Given this list of marker genes CLEC3B, SLITRK2, ACTN2, GCN1, SPACA3, NOS1, RAB6B, ADGRE4P, HNRNPH3 (NCBI Gene Id 3189), SUFU (SUFU negative regulator of hedgehog signaling), MIR185, CES2, COL14A1, BAALC, IGLL1, ADAT1, ALPK2, FOXN3, TRAM2, STAT3, POLR1D, FUT11, MYLIP, PAQR5, PHOX2B (NCBI Gene Id 8929), CAPZA3, DDX5, PJVK, ODAD4, MEGF6, ELMOD1, WDR33, SLC30A8, SPATA3, KRT6A (keratin 6A), MTHFD2L, AGAP2, TSC22D3, NUP210, SLC20A1, KBTBD12, SLC23A2, MAPDA, RHBDL1, ADCY8, TRIM40, C5AR2, GPC2, LRRC7 (NCBI Gene Id 57554), P2RX2, ANK2, ELN, PYGM, DYRK1B, ECT2L, GSDME, ANKRD61, AMDHD1, HEATR5B, FGF23, ETV2, FAT3, SNX29, XKR7, ANKRD60, SLC25A18, GDPD3, AGER, SLC6A5, FAM170B, SEMA3D, ZFP3, KDSR, WAS, SLC27A5, FGD5, SF3B1 (splicing factor 3b subunit 1), MIR376B, RGS7, KHSRP, RNF123, TRAK1, NOXO1, GLDN, SLC16A2, PAF1, MRAP2, VAMP2, CYB561D1, PRRT1, FAM83A, CNGA1, ZNF483, COX8BP, CREG2, HECW1, FHOD1, FRMD6, MIR337 (NCBI Gene Id 442905), CPEB1, NAA11, IDS, PSD4, FAM114A2, ZBTB44, NDOR1, TNNI3, NIPAL1, TMCC1, GALP, SAA2, TBX6 (NCBI Gene Id 6911), MST1, MIR181D, CLCA4, PRPS1L1, SPRR3, TTR, RTBDN, NLK, NEUROD2, CSRNP2, HAVCR1, FILIP1, NGFR, ANKFY1, MIR488, here is a description of the gene set: species: Homo sapiens The cytokine interleukin-12 (IL-12) is known to play a central role in adaptive and innate immunity. We employed microarray analysis of IL-12 induced gene expression to provide further insights into its effects on immune response. Genes down-regulated in peripheral blood monocytes (PBMC): control versus IL-12 stimulation. Human Gene Set: GSE12839_CTRL_VS_IL12_TREATED_PBMC_DN from publication Watford WT, Hissong BD, Durant LR, Yamane H, Muul LM, Kanno Y, Tato CM, Ramos HL, Berger AE, Mielke L, Pesu M, Solomon B, Frucht DM, Paul WE, Sher A, Jankovic D, Tsichlis PN, O'Shea JJ (PMID 19001140)